Given this list of marker genes OCRL, PSMB8, PSMB4, MMP2, TRAPPC2, here is a description of the gene set: Enlargement of the soft tissues of one or more fingers. studied in species Homo sapiens Finger swelling Human Gene Set: HP_FINGER_SWELLING